The following is a description of a gene set: Melena The passage of blackish, tarry feces associated with gastrointestinal hemorrhage. Melena occurs if the blood remains in the colon long enough for it to be broken down by colonic bacteria. One degradation product, hematin, imbues the stool with a blackish color. Thus, melena generally occurs with bleeding from the upper gastrointestinal tract (e.g., stomach ulcers or duodenal ulcers), since the blood usually remains in the gut for a longer period of time than with lower gastrointestinal bleeding. Human Gene Set: HP_MELENA species: Homo sapiens, and this is the list of marker genes: WAS, ITGA2B, CDKN1A, ACVRL1, FAH, MEN1, CD109, BMPR1A, ENG, KIF23, F9, APC, ITGA2, CDKN1B, ATRX, GP1BB, GP1BA, CDKN2B, RACGAP1, ITGB3, SREBF1, F8, CDKN2C, PTEN